The following is a description of a gene set: Human Gene Set: MIR4457 Genes predicted to be targets of miRBase v22 microRNA hsa-miR-4457 in miRDB v6.0 with MirTarget v4 prediction scores > 80 (high confidence targets). from publication Chen Y, Wang X (PMID 31504780) species: Homo sapiens, and this is the list of marker genes: CDK19, TENT5A, TSC22D2, FMO2, BCL2L1, CDK14, ACSF2, PATZ1, CCPG1, GATAD2A, REV1, SCG3, SLX4, PPP3CA, RTKN, PROS1, RNF217, SNX2, TNFSF14, RIMS1, PCDH17, IRF2, CHUK, ELAVL1, FADD, GMFB, LIPH, ADGRA1, RASSF2, TMED10, ZNF182, NEXMIF, NUS1, TOP3A, VAPA, NCOA2, CAMKV, KCNN3, PALM2AKAP2, JADE1, CMKLR2, BSN (NCBI Gene Id 90068), DR1, MAD1L1, AKAP6 (NCBI Gene Id 9472), TRAPPC2, DHX38, NEU1, ST8SIA3, RAD51AP1, NYAP2, FAM131B, STAM2, ARGLU1, KCNK10, RPRD1A, SF3B1, ZNF585A, RNF170, CDC14B, AFMID, CPSF6, PACRG, MTMR4, TEP1, KMT2A, ZC3HAV1, PIK3C2B, ZBTB41, PFN2, TRAF3, TRIP13, ZNF490, CETN3, KRTAP9-9, MED13L (NCBI Gene Id 23389), APC (APC regulator of WNT signaling pathway), PDE7B, TNFRSF10C, SRP72, CAMLG, KBTBD8, SPATA2, MOAP1, NEGR1, ZIC2, APOL4, ANKRD27 (ankyrin repeat domain 27), COPG2, SPTLC1, MAT2A, HMGB3 (NCBI Gene Id 3149), MDH1, NHS, RAB21 (RAB21, member RAS oncogene family), TTC17, TP53RK, HIGD1A, STX2, ACER3, GPR85, YWHAQ, PGM3, CASP10, SYT13, DLGAP1, SVEP1, UBE2D2, HOXA5, SOBP, FSTL5, PEG10, TEX36, KLF10, ADCY10, ILDR2, ADAR, SEPSECS, CES4A, DNAAF4, METTL21A, AHSA2P, ZC3H12D